The following is a description of a gene set: Cation-coupled Chloride cotransporters studied in species Homo sapiens Human Gene Set: REACTOME_CATION_COUPLED_CHLORIDE_COTRANSPORTERS, and this is the list of marker genes: SLC12A5, SLC12A7, SLC12A1, SLC12A4, SLC12A6, SLC12A3, SLC12A2